The following is a description of a gene set: Reactome Pathway: Negative regulation of MAPK pathway species: Mus musculus electronically inferred by orthology from the curated human pathway This event has been computationally inferred from an event that has been demonstrated in another species.<p>The inference is based on the homology mapping from PANTHER. Briefly, reactions for which all involved PhysicalEntities (in input, output and catalyst) have a mapped orthologue/paralogue (for complexes at least 75% of components must have a mapping) are inferred to the other species. part of: RAF/MAP kinase cascade, and this is the list of marker genes: Dusp6, Dusp16, Pebp1, Dusp5, Rps27a, Map2k1, Ppp2r5b, Mapk12, Hras, Ubb, Dusp2, Dusp9, Ppp2r5d, Mapk3, Ptpn3, Dusp7, Ppp5c, Map2k2 (NCBI Gene Id 26396), Ppp2r1b, Ptpn7, Brap, Ppp2r5a